Given this list of marker genes RC3H2, DENND5B, PDE10A, GRM5 (NCBI Gene Id 2915), ZEB2 (NCBI Gene Id 9839), RXYLT1, MYCT1, ADGRL3, RPS6KA6, TAFA2, ERC2 (NCBI Gene Id 26059), ASAH2B, LPGAT1, FNIP1, NRP1, FAT3, TLCD4, RGPD5, SNTG1, TIA1, GK5, CADM1, FOXJ2, TSC22D2, GAS1, TSPAN7, TRDMT1 (tRNA aspartic acid methyltransferase 1), NR2C2, OXR1, JAG2, SUMO2, SALL1, LOXL4, TAPT1, ATP5PF, SREK1, PPTC7, URI1 (URI1 prefoldin like chaperone), NQO1, VAPB, UPF1, SLC22A23, VPS13A, KLHL4, ATP6AP2, TEX30, GOLGA4, AVL9, KLLN, ANTXR2, MAP7, ZNF680, FXR1, PSD3, FHL1, AKAP11, CTNNA3, AKAP6, FAM169A (family with sequence similarity 169 member A), NAA30, MOB1A, CETN3, ATL3, KRTAP4-11, KAT6A, YWHAE, TMEM245, RAB10, KLF7, DNAJB9, GPATCH2L, RP2, CREBRF, FLI1, USF2 (NCBI Gene Id 7392), PPP1CB, REEP3, STXBP5, OSBPL8, ZNF468, ZBTB41, DMD, RGPD4, LRATD2, RGPD8, TMEM183BP, SUMO1, MAPK10, ARFGEF1, KRT10, PLXDC2, GNAI1, PUM1, ABRAXAS2, JADE2, RCOR3, HMGA2, VWA3B, MORF4L2, TCEAL8, FSD1L, CXCL13, EDNRB, ZC3H12B, RUFY3, LIN7C, SON, RNF2, SYNPO2, PREPL, ZNF217, TMEM260, SRSF10, USP25, ACTR3, NIPA2, SCN9A, CDYL2, PHF8, CCDC82, OTULIN, RIOK1, TRIM5, BIVM, AMPH, ASPH, PRKAR2B, POF1B, SYT14, CDK19, ZMYM4, TRIM9, RAD54B, PRP4K, SLC16A9 (NCBI Gene Id 220963), HSD17B11, ATP2B4, NCAM1, BBX, LUC7L3, FKBP5, DIAPH3, LRP6, TBL1XR1, TAF7L, SMIM13 (NCBI Gene Id 221710), CXXC4, KCNJ13, SIM1, ATF7IP, NFAT5 (NCBI Gene Id 10725), DNM3, NLGN1, EIF2S1, MAGEB4, TIMM29, EIF3M, PCDHB4, HIVEP2, UGCG, SOX11, CYREN, UBE2W, PCMTD1, API5, NHS, EPB41L4A, IKZF2, PHACTR4 (NCBI Gene Id 65979), RBMXL1, CEP85L, RBBP5, PDGFA, PARM1, PRKAR2A, PPM1K, EDEM1, SLC25A32, KMT5B, SCN1A, EEF1E1, TEAD1, OR7D2, SLC2A14, CETN2, ATAD1 (ATPase family AAA domain containing 1), RGS13, BCAT1, ORC5, TMEM200A, RFXAP, LRRC49, RYR2, TUT4, P2RY14, OPRM1, QKI, MON2, PHACTR3, DHX15, DUSP7, GOLT1B, GBP4, NFASC, CEP170, MEST, ZNF451, RNF182, GPR37 (NCBI Gene Id 2861), MICAL2 (NCBI Gene Id 9645), ARMC2, LATS2, GPR143, ERCC4, RIMOC1, CAPS2, TMEM47, MOB1B, PHF21A, NEXMIF (neurite extension and migration factor), DENND4A, HIF1A, SRSF3, RIOK3, SLC26A2, PSME4, MEF2C, TFEC, ZNF320, PAG1, LRRC8B, CPEB3 (cytoplasmic polyadenylation element binding protein 3), PDIK1L, NEK7, ARHGAP21, TIGAR, SLC2A3, KIAA1143, CSRNP2, GOLGA6L9, NRF1, SLC36A4, CACNB4, NAPB, PLRG1, TJP1, SCN7A, TRAM1L1, HOXC4, SLFN13, SELENOP, TMEM170B, TAOK1, TARDBP (TAR DNA binding protein), PERP, CBL, PPIC, ZDHHC21 (zinc finger DHHC-type palmitoyltransferase 21), ZNF24, SMURF1 (NCBI Gene Id 730332), GOPC, PDP2, ST13, P2RY10, BCOR, STK17B, INSYN2A (inhibitory synaptic factor 2A), RPRD1A, ASB11, GSTCD, MCFD2, MACROH2A1, ALCAM, ST6GALNAC5, DYNC1I2, C21orf91, EXT1, ITGA6, GRIA3, WDR45B, LIN7A, STEAP2, CREBBP, LONRF2, B3GALNT2, PRKG1 (protein kinase cGMP-dependent 1), AGK, MAP2, TNIK, CAMSAP2, EIF2D, NAA16 (NCBI Gene Id 79612), ELMOD2 (ELMO domain containing 2), MAP3K2, RFC5, STX18, ANKRD28, LGSN, TSR1, PCSK5, FEZ2, CCDC32, GARRE1, IFNA8, TMED4, CEPT1, CBX3, ARAP2, MITF, INO80D, C5orf24, HMGCR, FRMD6, CHIC1, CPNE5, CBLB, GLT8D2, CUL5, TMOD1, NBEA, ERI2, FHDC1, TNKS2, MAP4K3, POLD3, ZNF699, RUNX1T1, CNTNAP2, EYS, HOOK3, SIX4, FSBP, PTPRK, TSPYL5, ZNF503, MTF1, SCAI, PHC3, RIMS2, LAMA4, HECW2, SIRT1, DICER1, SATB1, CUL3 (NCBI Gene Id 8452), ABCB10, ZIC3, RORA, PEG3, RGPD6, SLC24A2, CSTF2T, MBOAT1, ITGA4, FTH1, ABCC1, SMIM17, MSL2, ACBD7, KDM4D, PIK3CD, DMGDH, RB1CC1, ACER2, MGAT4A, PCGF5, LARGE1, ZBTB20, SCRN3, ABLIM1, SORT1, CAMTA1, TCEAL4, EPHA5, ONECUT2 (NCBI Gene Id 9480), ZNF131, GJA1, MAPK1IP1L, SCML2, CR1, PKD2, ZNRF3, MTCH2, LPAR5, GNGT1, TNRC6B, OTUD4, TMF1, SPRY3, CADM2, ARIH1, SLC6A11, MDGA2, CEP41, RAP2C, ARMC1, SP4, RIC8B, CASD1, CYBRD1, SIKE1, PRRC1, ANLN, TRAPPC8, DHX32, SEC62, ATG2B, HERPUD2, OPRK1, PLPPR4, SEPTIN8, ZNF608, TRAPPC10, FIGN, KCNJ6, PHF6, MAP3K9, SLC6A14, KERA, UGGT1, SAXO2, GRPEL2, MED26, TPR, TFAP2B, CHSY1, OTUD7B, FOXA1, PCMTD2, ASB15, SIAE, LIN54, PCSK1, ZNF566, CRIPTO, FMO3, BEND7, AAK1 (NCBI Gene Id 652453), PTGER3, PHIP, SESTD1, C1orf185, SESN3, LPIN2, PPARGC1A, TRPA1 (transient receptor potential cation channel subfamily A member 1), CFAP418, HMGB2, ATRX, GABRG1, FZD10, FAM220A, PIP4P2, TMEM183A, ARF6, ELAVL1, GFPT1, ERCC6L2, ZNF706, MACC1, DNAL4, PABPC1, ZNF148, CTSO, ARMC8, NECAP1, TMEM63B, CMPK1, TENM1, IRS1, IPO5, KCNQ5, UNC5C, AKAP5, ZNF644, LACTB, GCC2, DACH1, NETO1, TRIM2 (tripartite motif containing 2), FCHSD2, SLK, CCDC117, DGKH, ATG4C, DPY19L3, CIPC, LHX2, HIPK3, PTPN20, RPGR, NMNAT2, TGFBRAP1 (NCBI Gene Id 9392), CANT1, KRTAP4-8, VANGL1, FMO2, DUSP16, GABRA4, TDRP, RLIG1, ANKS1B, VAPA, TGFB2, SLC44A1, ATG5, IL17RD, RAB21, TMTC1, MEX3A, ITIH5, NCEH1 (NCBI Gene Id 57552), NECAB1, PDCD1LG2, GLRA2, here is a description of the gene set: studied in species Homo sapiens Human Gene Set: MIR3133 from publication Chen Y, Wang X (PMID 31504780) Genes predicted to be targets of miRBase v22 microRNA hsa-miR-3133 in miRDB v6.0 with MirTarget v4 prediction scores > 80 (high confidence targets).